Given this list of marker genes Srd5a3, Hsd17b10, Rdh7, Srd5a1, Akr1b8, Dhrs11, Hsd17b12, Nsdhl, Hsd17b13, Hsd17b7, Hsd3b8, Akr1b7, Hsdl1 (NCBI Gene Id 72552), Hsd3b4, Akr1c6, Hsd17b2, Akr1c19, Dhrs4, Akr1c20, Cbr3, Rdh19, Hsd17b14, Akr1c14, Dhrs9, Rdh9, Hsd3b2, Akr1c12, Hsd17b4, Hsd3b9, Rdh14, Hsd17b8, Hsd17b1, Akr1cl, Akr1d1, Akr1b10, Rdh16f2, Hsd17b3, Hsd11b1, Dhrs1, Rdh1, Srd5a2, Akr1c13, Hsd3b6, Hsd11b2, Hsd17b11, Hsd3b5, Akr1c21, Akr1c18, Rdh16, Hsd3b3, Hsd3b1, Hsd17b6, Rdh5, here is a description of the gene set: Catalysis of an oxidation-reduction (redox) reaction in which one substrate is a sterol derivative. studied in species Mus musculus Mouse Gene Set: GOMF_STEROID_DEHYDROGENASE_ACTIVITY